The following is a description of a gene set: studied in species Homo sapiens Human Gene Set: GOBP_REGULATION_OF_CHONDROCYTE_DEVELOPMENT Any process that modulates the rate, frequency, or extent of the process whose specific outcome is the progression of a chondrocyte over time, from its commitment to its mature state. Chondrocyte development does not include the steps involved in committing a chondroblast to a chondrocyte fate., and this is the list of marker genes: AXIN2, SMAD7, HOXA11, RFLNB, PTHLH, RFLNA